The following is a description of a gene set: Human Gene Set: GOBP_VESICLE_BUDDING_FROM_MEMBRANE The evagination of a membrane, resulting in formation of a vesicle. studied in species Homo sapiens, and this is the list of marker genes: CUL3, RAB7A, SEC24B, TRAPPC1, P2RX7, SNAP91, TMED9, SEC16A, SNX3, PRKCI, AP3S2 (adaptor related protein complex 3 subunit sigma 2), GOLPH3, MX1, TRAPPC2L, SEC24C, DNM1 (dynamin 1), SEC24A, TRAPPC3 (trafficking protein particle complex subunit 3), TRAPPC9, SCAP, FNBP1L, SEC31A, SEC23B, RAB1A, TFG, PRKN, AP1G1, AP3S1, CSNK1D, INSIG1, CHMP7, TRAPPC2B, SEC31B, AP2M1, S100A10, AP3B2, SURF4, PEF1, CHMP4B, AP3D1, SEC24D, VAPB, WASL, CIDEB, VAPA, CHMP5, TMED2, PICALM, AP3M2, SEC23A, ANXA2, SAR1B, KLHL12, RILP, CHMP4C, TRAPPC12 (NCBI Gene Id 51112), TRAPPC8, VPS4A, TRAPPC4, TBC1D20, TRAPPC13, GOLPH3L, CHMP4A, TRAPPC10, DNM3, MAPK15, PREB, TRAPPC11, PDCD6, TRAPPC5, PPP6C, SEC13, ARFGAP3, MX2, CHMP6, SLC2A4, BTBD8, MYO18A (NCBI Gene Id 9799), DNM2, SAR1A (secretion associated Ras related GTPase 1A), MIA3, TRAPPC6A, TRAPPC6B, CHMP4BP1, GBF1 (golgi brefeldin A resistant guanine nucleotide exchange factor 1), ARFGAP2, TRAPPC2, TMED10